Given this list of marker genes Odc1, Ldc1, Azin2, Azin1, Agmat, here is a description of the gene set: Mouse Gene Set: GOBP_PUTRESCINE_BIOSYNTHETIC_PROCESS_FROM_ARGININE The chemical reactions and pathways resulting in the formation of putrescine, 1,4-diaminobutane, from other compounds, including arginine. studied in species Mus musculus